The following is a description of a gene set: Although germline mutations of BARD1 are implicated in some cases of hereditary breast and ovarian cancer (HBOC), they occur less frequently that those of the BRCA1 or BRCA2 genes (De Brakeleer et al. 2010, Alenezi et al. 2020). From animal studies, it is known that the loss of BARD1 function results in a phenotype very similar to that caused by loss of BRCA1 function, characterized by embryonic lethality, genomic instability and defects in homology-directed repair. A small number of clinically-relevant BARD1 missense mutants that have been functionally characterized and shown to be impaired in BRCA1 binding are annotated in this pathway. studied in species Homo sapiens part of: Diseases of DNA Double-Strand Break Repair Reactome Pathway: Defective DNA double strand break response due to BARD1 loss of function, and this is the list of marker genes: BARD1, BRCA1